Given this list of marker genes Pglyrp4, Peli1, Flt3, Smarcd1, Mir326, Tac1, Runx3, Pf4, Kmt5b, Arid2, Syk, Nrarp, Lef1, Sos2, Sox13, Ppp2r3c, Lax1, Ptpn6, Lrrc32, Atm, Gas6, Prkar1a, Tyrobp, Thy1, Fcgr2b, Actl6a, Socs6, Arid1a, Il15ra, Cd80, Tbc1d10c, Cd37, Dtx1, Tlr4, Gimap3, B2m, Ikzf3, Braf, Cd47, Rag2, Bloc1s6, Btnl2, Shld2, Tnfsf4, Clec12a, Sh2d1b2, Tnfrsf1b, Cav1, Siglecg, Chrnb2, Smarcc2, Il7r, Pdcd1, Rps3, Scgb1a1, Ascl2, Cd209a, Nfkbid, Gata3, Sart1, Nkap, Hmgb1, Adora2a, Tnfrsf4, Smarcd3, Brd4, Vav1, Tmem131l, Il13, Tox, Mill1, Fas, Bcl6, Sirpa, Socs5, Il21, Cd40, Zfp609, Cd209d, Epo, Xcl1, Hfe, Pck1, Ceacam1, Xbp1, Pglyrp2, Pla2g2f, Dpp4, Nck1, Dusp10, Kcnk18, Mapk8ip1, Anxa1, Cd28, Rassf5 (NCBI Gene Id 98602), Foxj1, Pdcd1lg2, Brd7, Ephb6, Rhoh, Vcam1, Adam8 (a disintegrin and metallopeptidase domain 8), Il36b, Lep, Egr3, Tgfbr2, Carmil2, Nr5a2, Zc3h8, Cd274, Tcf7, Scrib, Il2rg, Prkcz (NCBI Gene Id 97193), Cd160, Tarm1, Hmgb3, Rc3h1, Kat5, Ap3b1, Tyk2, Dapl1, Dusp3, Csk, Samsn1, Lmo1, Smarcb1, Ccl19, Sox11, Ccl2, Ada, Ptprc, Cd244a, Ulbp1, Cd55b, Il2, Cd6, Abl1, Prdx2, Ddrgk1 (DDRGK domain containing 1), Tespa1, Phf10, Clec7a, Irs2 (NCBI Gene Id 384783), Sh3kbp1, Sh2b3, Clnk, Shld3, Zfp36l2, Tnfsf13b, Mettl3 (NCBI Gene Id 80554), Ppp3ca, Cd83, Zmiz1, Mpl, Shb, Vnn1, Slc46a2, Aif1, Rhbdd3, Slc15a4, Ccl20, Mzb1, Cd1d1, Znhit1, Zfp36l1, H2-Eb2, Clptm1, Tnfsf14, Smarca4, Slfn1, Il1rl2, Cd74, Msh2, Nckap1l, Fgl1, Cyrib, Bmi1, Flot2, Parp3, Tnfsf9, Akirin2, Mertk, Opa1 (NCBI Gene Id 74143), Cd209c, H2-Aa, Ctla4, Ticam1, Fcho1, H2-DMb2, Dhps, Rag1, Ripor2, H2-M3, Cdkn1a, Il1b, Lag3, Kat2a, Il7, Hmces, Ambra1, Spi1, Socs1, Cd59a, Prdm1, Fancd2, Duxbl1, Il6st, Pla2g5, Ufl1, Exosc3, Cd86, Smarcd2, Tcf3, Adrm1, Rac2, Pglyrp3, Cd22, Il20rb, Lgals1, Traf6, Raet1d, Erbb2, Rara, Il4i1, Cyld, Efnb2, Il12rb1, Tirap, Crtam, Coro1a, H2-Ea, Themis2, Sox12, Ager, Nlrp3, Aplf, Zeb1, Mdk, Zbtb1, Fanca, H2-Ab1, Lst1 (leukocyte specific transcript 1), Cyp26b1, Tyro3, Prnp, Ccr6, Mir181b-2, Mef2c, Lat, Ywhag, Zfp335, Pibf1, Abl2, Gli3, Stat5a, Spta1, Lilrb4a, Hes1, Marchf7, Itgal, Prkcq, Sfrp1, Ihh, Havcr2, Dlg1, Fgr, Nsd2, Actl6b, Zap70, Sdc4, Ifng, Mmp14, Il4ra, Efnb3, Btk, Fadd, Cd320, Pik3r6, Il27, Lgals3, Card11, Dnaja3, Rorc, Vsir, Bank1, Btn2a2, Lilrb4b, Nod2 (nucleotide-binding oligomerization domain containing 2), Ifnb1, Tfrc, Axl, Ido1, Sox4, Dusp22, Cd27, Lyn, Myd88, Foxn1, Cd4, Pagr1a, Pbrm1 (polybromo 1), Tnfsf18, Pglyrp1, Hps1, Hspb1, Prkaa1, Gpr183, Ccr7, Pde5a, Actb, Skint1, Tnfsf13, Pten, Cd3e, Il5, Gpnmb, H2-T23, Ccl21a, Trex1, Pnp, Zc3h12d, Clcf1, Il4, Zbtb7b, Il12b, Foxp3, Fbxo7, Xrcc6, Dicer1, Gpam, Cd44, Dlg5, Arg1, Slamf8, Il12a, Ptpn22, Sh3rf1, Cblb, Cbfb, Tnfaip3, Ap3d1, Arg2, Ahr, Malt1, Slc7a1, Ctnnb1, Cd55, Tgfb1, Tsc2, Pms2, Lgals8 (lectin, galactose binding, soluble 8), Shh, Bid, Tnfsf11, Ankle1, Bad, Rnf41, Pkn1, Zfp35, Pla2g2d, Gal, Smarca2, Lgals9, Il15, H2-Eb1, Tacr1, Cd19, Icosl, Mad1l1, Bloc1s3, Ighd, Cd69, Mir150, Mad2l2, Smad7, Klrd1, Clec4g, Il3, Ccl5 (C-C motif chemokine ligand 5), Atp11c, Trp53bp1, Igf1, Pycard, Laptm5, Vsig4, Ctla2a, Casp3, Sos1, Rasgrp1 (NCBI Gene Id 19419), Tbx21, Il10, Tlr9, H2-Ob, Tnfrsf13c, Smarcc1, Hsp90aa1, Exosc6, Rasal3, Csf1r, Ildr2, Cebpb, Loxl3, Atad5, Rif1, Cd46 (NCBI Gene Id 17221), BC037156, Il6, Spn, Nedd9, Ccr2, Tnfrsf21, Tnfrsf9, Pla2g2a, Slamf1, Kitl, Zfp683, Brd2, Smarce1, Tnfaip8l2, Drosha, Glmn, Vav3, Ripk2, Gnrh1, Cd40lg, Itch, Fgl2, Tnfrsf13b, Slc4a1, Inpp5d, Dcaf15, Il23a, Ndfip1, Tnip2, Pag1, Rc3h2 (NCBI Gene Id 77277), Zp3, Zfp608, Gimap5 (NCBI Gene Id 319541), Btla, Stat5b, Slc39a10, Supt6, Zc3h12a, Mlh1, Nfkbiz, Bst1, Tnfrsf14, Vtcn1, Cd81, Clec2i, Cd38, Nfatc2, Wnt10b, Ccdc88b, Il2ra, Flt3l, Nfam1, Cd59b, Igf2, Cd5, Irf1, Ep300, Dock8, Cdkn2a, Ephb2, Ripk3, Cgas, Wnt3a, Prkdc, Hsph1, Jak3, Shld1, Ptpn2, Sit1, Klhl22, Runx1, Cd300a, Cd1d2, Icos, Cd276, Foxo3, Cd24a, Sash3, Blm, Stat6, Twsg1, Slc4a2, Efnb1, H2-DMb1, Slamf7, Prlr, H2-DMa, Tigit, Mir301, Paxip1 (PAX interacting (with transcription-activation domain) protein 1), Hlx, Sftpd, Bcl10, Pawr, Ctsg, Tspan32, Mir181b-1, Fgf10, Id2, Itpkb, Adk, Lck, Fbxo38, Igfbp2, Kmt5c, Klhl25, Irgm1, Nck2, Ephb4, Mif, Il1a, Jak2, Selenok, H2-Oa, Cd209e, Ighm, Prelid1, Lyst, Il27ra, Bmp4, Il18, Hspd1, Bcl2, Pcid2, Rhoa, here is a description of the gene set: species: Mus musculus Any process that modulates the frequency, rate or extent of lymphocyte activation. Mouse Gene Set: GOBP_REGULATION_OF_LYMPHOCYTE_ACTIVATION